Given this list of marker genes Mtap, Aprt, Hprt1, Adk, Pgm2, Pnp (purine-nucleoside phosphorylase), here is a description of the gene set: Any process which produces a purine nucleoside from derivatives of it, without de novo synthesis. Mouse Gene Set: GOBP_PURINE_RIBONUCLEOSIDE_SALVAGE studied in species Mus musculus